Given this list of marker genes GLB1, CTSA, NEU1, ASAH1, HEXB, YME1L1, FUCA1, PSAP (NCBI Gene Id 83009), GALC, HEXA, DARS1, SMPD1, GM2A, here is a description of the gene set: Human Gene Set: HP_CHERRY_RED_SPOT_OF_THE_MACULA Cherry red spot of the macula studied in species Homo sapiens Pallor of the perifoveal macula of the retina with appearance of a small circular reddish choroid shape as seen through the fovea centralis due to relative transparency of the macula.